The following is a description of a gene set: Genes predicted to be targets of miRBase v22 microRNA mmu_miR_191_5p in miRDB v6.0 with MirTarget v4 prediction scores > 80 (high confidence targets). Mouse Gene Set: MIR_191_5P from publication Chen Y, Wang X (PMID 31504780) studied in species Mus musculus, and this is the list of marker genes: Tjp1, Mapre3, Tmod2, Cebpb, Wiz, Map3k12, Sall1, Taf5, Plcd1, Chmp5, Jph3, Neurl4